Given this list of marker genes Ubqln1, Ltv1, Foxk2, Nifk, Ripor2, Aars1, Sec23b, Manf, Pelo (NCBI Gene Id 105236), Xpnpep1, Eprs1, Lrp2, Stip1, Kras, Stx12, Npl, Timm8a1, Ncbp1, Actl6a, Myrf, Septin4, Cycs, Nucb2, Synpo, Hsp90b1, Dus1l, Nop56, Ddx21, Usp39 (ubiquitin specific peptidase 39), Ftsj3, Aldh1a2, Gnl3, Tars1, Utp4, Gspt1, Homer2, Hspa5, Gmppb, Mars1, Igf1, Tfrc, Hdc, Rdx, Acot7, Bysl (bystin-like), Gli1, Rrs1, Hif1a, Srsf3, Gm33887, Tsr1, Mettl1, Pum3, Srm, Srrt (NCBI Gene Id 83701), Psme3, Il13ra2, Mrto4, Nop58, Rraga, Hnrnpll, Dnajb11, Olfm1, Ddx51, Ppan, Farsb, Pus1, Kpna2, Pex11a, Ndufaf4, Pla2g10, Creld2 (NCBI Gene Id 97988), Srsf2, Cse1l, Epb41, Bop1, Pdia6, Areg, Becn1, Lgalsl, Ctla2a, Slc35b1, Tmem9b, Strap, Abce1, Tubb2a, Pa2g4, Cdo1, Ak6, Bms1, Mak16, Cad, Adh5, Pno1, Selenos, Gstm1, Gstm3, Ipo7, Clcn5, Tnfrsf21, Rangrf, Amd-ps1, Lrrc59, here is a description of the gene set: Genes co-regulated in uterus during a time course response to progesterone: SOM cluster 11. Mouse Gene Set: YAO_TEMPORAL_RESPONSE_TO_PROGESTERONE_CLUSTER_11 studied in species Mus musculus Human infertility and recurrent pregnancy loss caused by implantation defects are poorly understood. Hoxa-10-deficient female mice have severe infertility and recurrent pregnancy loss due to defective uterine implantation. Gene expression profiling experiments reveal that Hoxa-10 is an important regulator of two critical events in implantation: stromal cell proliferation and local immunosuppression. At the time of implantation, Hoxa-10 mediates the progesterone-stimulated proliferation of uterine stromal cells. Hoxa-10 mutants express a stromal cell proliferation defect that is accompanied by quantitative or spatial alterations in the expression of two cyclin-dependent kinase inhibitor genes, p57 and p15. Hoxa-10 deficiency also leads to a severe local immunological disturbance, characterized by a polyclonal proliferation of T cells, that occurs in place of the normal progesterone-mediated immunosuppression in the periimplantation uterus. from publication Yao MW, Lim H, Schust DJ, Choe SE, Farago A, Ding Y, Michaud S, Church GM, Maas RL (PMID 12554760)